The following is a description of a gene set: Genes up-regulated during B lymphocyte differentiation: pre-B I versus small pre-B II. species: Homo sapiens Cells from four develppmental stages were purified by FACS from human bone marrow samples Human Gene Set: GSE4590_PRE_BCELL_VS_SMALL_PRE_BCELL_UP from publication Hoffmann R, Lottaz C, Kühne T, Rolink A, Melchers F (PMID 17890238), and this is the list of marker genes: CDC42BPG, SLA, SV2C, NECTIN2, SLC30A4, HEBP1, BCORL1, KRT28 (keratin 28), FAM135A, SLC44A4, TTC8, SMURF1, RNF6, GRIN2D, CCDC120, DSE, ARHGAP5, AIG1, IFI44, OCIAD2, PRKCB, RHOBTB1, HSPB1, BEND5, TBC1D12 (NCBI Gene Id 23232), ATP11A, ACSF2, SCAMP5, RAB39A, PLEKHA5, SFMBT2, RNF135, RCOR2, RAB34, PIGZ, ANKFY1, FEZ2, ARHGEF12, HLX, NOD1 (nucleotide binding oligomerization domain containing 1), GTPBP2, MAGOHB, ADGRG6, RCN1, ALKBH6, FMO2, GRK2, GNB4, TMEM175, ALDH1L1, TRIM14 (NCBI Gene Id 9830), NCS1, ORC3, CST9, ST6GAL1, TMEM9 (NCBI Gene Id 51235), PSME1 (NCBI Gene Id 5720), BICD1, ZDHHC23, MYCT1, RBMY1A1, RECK, TGM5, MESP1, SETMAR, AKAP11, MIF4GD, PTPDC1, FOXJ2, FOXO1, PDE3B, TCL1A, IDO1, PCGF2, ZHX3, HMGN1, TCF7L2, OTUB2, PLCL1 (NCBI Gene Id 5334), QSOX1, NAPB, PVT1, LRGUK, TMED1, FLVCR2, STAU2, USP11, RABGAP1L, IL3RA, ZNF318, AGO4, PHF11, POGK, STBD1, ACAD8, CD2AP, KCTD3, SSH1, SLC2A3, KLC2, AMIGO1, CRLF3, SYNCRIP, METTL27, TANC2 (NCBI Gene Id 80259), CAND2, FKBP14, MAGED2, ATXN1L, CCDC91, PLCG1, CLTRN, FBXO39, P2RY14, SUGP1, CMTM4, CD63, RAB13, PTGS1, RAC3, TLR3, PFN2, EIF5A2, ANO4, SPATS2, RNF139, DTX3, PDLIM4, HECTD2, MAGEE1, H1-10, CD81, MEX3A, MFSD9, GARIN2, FMNL2, SLC12A2, MIER2, AHR, GKAP1, IMMP2L, SLN, PIGP, ABCA5, TSPAN12, SCN3B, MAGED1, ZDHHC15, DHX40, PLOD2, GBP6, TAF9B, SLC17A6, ACY1, NENF